The following is a description of a gene set: Up-regulated genes from the optimal set of 550 markers discriminating breast cancer samples by ESR1 expression: ER(+) vs ER(-) tumors. studied in species Homo sapiens Human Gene Set: VANTVEER_BREAST_CANCER_ESR1_UP Breast cancer patients with the same stage of disease can have markedly different treatment responses and overall outcome. The strongest predictors for metastases (for example, lymph node status and histological grade) fail to classify accurately breast tumours according to their clinical behaviour. Chemotherapy or hormonal therapy reduces the risk of distant metastases by approximately one-third; however, 70-80% of patients receiving this treatment would have survived without it. None of the signatures of breast cancer gene expression reported to date allow for patient-tailored therapy strategies. Here we used DNA microarray analysis on primary breast tumours of 117 young patients, and applied supervised classification to identify a gene expression signature strongly predictive of a short interval to distant metastases ('poor prognosis' signature) in patients without tumour cells in local lymph nodes at diagnosis (lymph node negative). In addition, we established a signature that identifies tumours of BRCA1 carriers. The poor prognosis signature consists of genes regulating cell cycle, invasion, metastasis and angiogenesis. This gene expression profile will outperform all currently used clinical parameters in predicting disease outcome. Our findings provide a strategy to select patients who would benefit from adjuvant therapy. from publication van 't Veer LJ, Dai H, van de Vijver MJ, He YD, Hart AA, Mao M, Peterse HL, van der Kooy K, Marton MJ, Witteveen AT, Schreiber GJ, Kerkhoven RM, Roberts C, Linsley PS, Bernards R, Friend SH (PMID 11823860), and this is the list of marker genes: STARD10, DNAJC12, IL6ST, SCCPDH, TP53INP1, IGFBP4, ESR1, MRPS27, BAG1 (NCBI Gene Id 573), SCUBE2, CCDC74B, MYB, OVOL2, NEK9, GFRA1, FAAH, DNALI1, FUT8, PTPRT, UGCG, SYNGR1, MINDY1, ERBB3, BCL2, HMGCL (3-hydroxy-3-methylglutaryl-CoA lyase), LZTFL1, GPD1L, LRIG1, CISH, COX6C, ABCA3, NHERF1, HTT, IGBP1, TOGARAM1, CA12, TSPAN13 (tetraspanin 13, NCBI Gene Id 27075), ITPK1, AFF1 (NCBI Gene Id 83116), VAV3, SPDEF, CHD6 (chromodomain helicase DNA binding protein 6), CERS2, SCAMP1, FAM110C, MCCC2, C4A, DELE1, ECI1, CIRBP, FAN1, SYBU, SPEF1, PTP4A2, CYB5R1, EEIG1, P4HTM, EML2, SEC14L2, CXXC5, TPBG, DBNDD2, GLI3, C3orf18, KIAA0232, PREX1, PEX19, KRT18, EVA1B, INPP5J, APPL2, CCNG2, XBP1, PIGT (NCBI Gene Id 94004), MEIS3P1, CELSR1, HDAC11, GREB1, RARA, HSD17B4, MACIR, KIF16B, ZBTB40, TMBIM4, QDPR, FOXA1, LAMB2, GADD45G, LRBA, NEDD4L, ACADSB, CAMLG, KDM4B, NAT1, MAN2B2, ERBB4, FGD3 (NCBI Gene Id 89846), LONRF2, CCDC106, CHAD, ELOVL5, SLC39A6, MYLIP (NCBI Gene Id 29116), SLC16A6, FBP1, FAM174B, GPR162, SKP1P1, EVL (NCBI Gene Id 51466), RNF103, SLC35E2B, SREBF1, HEXIM1, NPDC1 (neural proliferation, differentiation and control 1), PPP1R26, TBC1D9, SNX1, MYO5C, TMBIM6, HHAT, ABAT (4-aminobutyrate aminotransferase), TCEAL1, RETREG1, PBX1, AQR, ZNF587, MAST4, FARP2, TUSC2, IRS1, KCTD3, GATA3, PCSK6, KIF13B, RAB11FIP3, MED13L, BTF3, TFF3, MREG, BTBD9, CERS6, HNRNPA1 (heterogeneous nuclear ribonucleoprotein A1), BRD8, BHLHE40, RBM47, CHRD, WDR6, SOX12, MAGED2